Given this list of marker genes Tarbp2, Dicer1, Ago4, Trub1, Lin28b, Dgcr8, Ago2, Prkra, Tut7, Ago1, Bcdin3d, Ago3 (NCBI Gene Id 320115), Lin28a, Adar, Drosha, Tut4, here is a description of the gene set: A process involved in the conversion of a pre-microRNA transcript into a mature microRNA molecule. species: Mus musculus Mouse Gene Set: GOBP_PRE_MIRNA_PROCESSING